The following is a description of a gene set: Human Gene Set: GOBP_POSITIVE_REGULATION_OF_EXTRINSIC_APOPTOTIC_SIGNALING_PATHWAY Any process that activates or increases the frequency, rate or extent of extrinsic apoptotic signaling pathway. species: Homo sapiens, and this is the list of marker genes: BID, CAV1, CD40LG, BMPR1B, PML, RIPK1, PEA15, SKIL, LTA, LTBR, TNFSF12, SFRP1, PAK2, BCL2L14, CTNNA1, PPP2R1B, ITM2C, TNFSF11, RET, APP, FASLG (NCBI Gene Id 356), TNF, TRAF2, PDIA3, BCL10, CYLD, TLR6, SRPX, ATF3 (activating transcription factor 3), AGT, TNFSF14, MAL, PYCARD, ZSWIM2, GPER1, RBCK1, FADD, TLR4, HTRA2, PPP2R1A, HYAL2, TNFSF10, THBS1, STK3 (serine/threonine kinase 3), TNFSF15, INHBA, NF1, TNFRSF12A (TNF receptor superfamily member 12A), AGTR2, FAF1, STK4, G0S2, TGFB2, PPP1CA, PTPRC, DEDD2, LTB, WWOX, PMAIP1